Given this list of marker genes Ildr2, Gigyf2, Akt3, Klhl10, Bcl2, Prdm14, Elp6, Nos3, Gata1, Il7, Fsip1, Nfkbiz, Kmt2a, Kras (NCBI Gene Id 232521), Bax, Rpa1, Ccr2, Tex15 (NCBI Gene Id 73664), F2r, Csf1, Add1, Rac1, Gata2, Flt3l, Minar2, Cd7, Pth, Nfix, Lipa, Epg5, Tuba1a, Epsti1, Sash3, Trgc1, Vegfa, Vps54, Col14a1, Rac3, Flt3, Vhl, Pantr2, Xiap, Prdx5, Fosl2, Gnat2, P2rx7, Smo, Sox9, Fh1, Notch1, Coro1a, Exoc5 (exocyst complex component 5), Brinp1, Ptpn11, Il20rb, here is a description of the gene set: species: Mus musculus Mouse Gene Set: GOBP_HOMEOSTASIS_OF_NUMBER_OF_CELLS_WITHIN_A_TISSUE Any biological process involved in the maintenance of the steady-state number of cells within a population of cells in a tissue.